Given this list of marker genes RFPL1, LMNA, DAP3, SLC7A5, SMOX, PSMD11, HSPA1A, ZRSR2, DHRS3, HSPA9 (heat shock protein family A (Hsp70) member 9), FLNC, SERPINB8, CCPG1, ALDH1A2, CALCA, MXD1, TNFRSF10B, PTPRN, MAGEB1, PLAAT3, DUSP1, GDF7, CASP7, RIT1, KIF1B, DYNC1H1, BBC3, COL16A1, NTS, MAP1A, PCYT1B, SYT2, STX6, CDK11B, GADD45G, ABLIM3, SLC12A4, THBS4, YKT6, IFRD1, TOM1, EIF5, DNAJC2, KITLG, ACTA2, GPX3, CEBPG, DNAJB4, ATP2B4, DUSP4, RHBDD3, DNAJB2, PHTF1, MBOAT7, NSFL1C, PSMA5, ITGA7, HSPA4L (NCBI Gene Id 22824), PLD3, POLR3C, ELL2, MIR22HG, LAMP3, STK17A, MAP1LC3B, BAK1 (NCBI Gene Id 578), MEST (NCBI Gene Id 95680), UBFD1, CAMK2G, KLHL21 (NCBI Gene Id 9903), PRSS12, GCLM, WARS1, MICB, TNFSF9, ACHE, PRDM2, ICAM2, GABARAPL1, KCTD20, CDKN1A, JMJD6, ZNF10, SUSD5, CDR1, ZFP36 (ZFP36 ring finger protein), SYNJ2, SRP19, HSPA4, CHM, PDLIM3, LRIG1, SPATA2, GLS, INPP5D, ANXA2, LIN37, SLC16A3, CCNT2, SKIL, GLRX3, SAT1, LPXN, ADRM1, SQSTM1, GLA, AKAP6, FOS, CYP4F2, GADD45A, UFD1, TGFBR2, BSCL2, TTC1, ORC3, C1S (NCBI Gene Id 716), UPP1, MDM2, ACADVL, NQO1, GEM, NEAT1, DUSP3, FAT1, RRAD, SLC7A1, ARK2N, TNKS, DDIT3, IL11, MAFF, ENSG00000275616, SERPINE1, ABHD3, ATF3, GTF2A1, SSX1, SMG1, SEL1L3, GDF15, NACC2, RAB36, SERPINH1, HEG1, STIP1, DGKE, PPP1R15A, ZYX, LDAF1, LGALS8, MAP1B, GOSR2, PSMD1, SLC38A6, TOP3B, CYB5R1, TUBA4A, STX16, N4BP2L2, DOK1, MSX2, HSPA6, NUCB1, AQP3, CREB5, KLF6, AKR1C1, TNPO2, PHLDA2, KIAA0319, IL15, SLCO3A1, CTH, CLU, CREM, PHKG2, TAC1, PCYT1A, DNAJB1, UBE2H (ubiquitin conjugating enzyme E2 H), PGF, NQO2, DTNA, TSPYL2, JUN, DNAJB6, HMOX1, ME1, ARHGEF2, EPCAM, IDE, PRKCZ, PSMD13, AKR1C3, TSPAN9, CYP4F3, SLC3A2, CAP2, HSPB1, MAP2, SNRK, TAF13, F2RL1, BLVRB, PLK2, CLTB, GSR, FAS, KIAA0930, TOP6BL, TMF1, TTC39A (tetratricopeptide repeat domain 39A), EPB41 (erythrocyte membrane protein band 4.1), LMO2, FILIP1L (filamin A interacting protein 1 like), SLC7A11, HSPH1, WWTR1, SYCP2, PLAT, PCSK1, CEBPB, PSMD12, PXDC1, SPP1 (NCBI Gene Id 6696), DYNC1I1, UBR4, CEP170B, BCL2L11, P4HA2, MAP3K14, RAB21, ZFR, PALLD, ABCG1, SSX2, CD44, IL6R, ZNF185, here is a description of the gene set: Genes up-regulated in SH-SY5Y cells (neuroblastoma) after treatment with epoxomicin, a protease inhibitor causing apoptosis. Human Gene Set: CONCANNON_APOPTOSIS_BY_EPOXOMICIN_UP The proteasome has emerged as a novel target for antineoplastic treatment of hematological malignancies and solid tumors, including those of the central nervous system. To identify cell death pathways activated in response to inhibition of the proteasome system in cancer cells, we treated human SH-SY5Y neuroblastoma cells with the selective proteasome inhibitor (PI) epoxomicin (Epoxo). Prolonged exposure to Epoxo was associated with increased levels of poly-ubiquitinylated proteins and p53, release of cytochrome c from the mitochondria, and activation of caspases. Analysis of global gene expression using high-density oligonucleotide microarrays revealed that Epoxo triggered transcriptional activation of the two Bcl-2-homology domain-3-only (BH3-only) genes p53 upregulated modulator of apoptosis (PUMA) and Bim. Subsequent studies in PUMA- and Bim-deficient cells indicated that Epoxo-induced caspase activation and apoptosis was predominantly PUMA-dependent. Further characterization of the transcriptional response to Epoxo in HCT116 human colon cancer cells demonstrated that PUMA induction was p53-dependent; with deficiency in either p53 or PUMA significantly protected HCT116 cells against Epoxo-induced apoptosis. Our data suggest that p53 activation and the transcriptional induction of its target gene PUMA play an important role in the sensitivity of cancer cells to apoptosis induced by proteasome inhibition, and imply that antineoplastic therapies with PIs might be especially useful in cancers with functional p53. from publication Concannon CG, Koehler BF, Reimertz C, Murphy BM, Bonner C, Thurow N, Ward MW, Villunger A, Strasser A, Kögel D, Prehn JH (PMID 16983338) studied in species Homo sapiens